Given this list of marker genes Elovl5, Elovl6, Far1, Far2, Acot7, Elovl7, Dgat1, Elovl3, Acot2, Elovl1, Acsl6, Acsl4, Elovl4, Dgat2, Them5, Acsl5, Acsl3, Acsl1, here is a description of the gene set: Mouse Gene Set: GOBP_LONG_CHAIN_FATTY_ACYL_COA_METABOLIC_PROCESS studied in species Mus musculus The chemical reactions and pathways involving long-chain fatty-acyl-CoAs, any derivative of coenzyme A in which the sulfhydryl group is in a thioester linkage with a long-chain fatty-acyl group. A long-chain fatty acid has an aliphatic tail containing 13 to 22 carbons.